Given this list of marker genes ATP11A, TMEM30A, ATP8A2 (ATPase phospholipid transporting 8A2), ATP8A1, ATP11C, ATP8B1, TMEM30B, here is a description of the gene set: Enables the transfer of aminophospholipids from the exoplasmic to the cytosolic leaflet of a membrane, using energy from the hydrolysis of ATP. Aminophospholipids contain phosphoric acid as a mono- or diester and an amino (NH2) group. Human Gene Set: GOMF_AMINOPHOSPHOLIPID_FLIPPASE_ACTIVITY studied in species Homo sapiens